The following is a description of a gene set: Male steroid hormones in cardiomyocyte energy metabolism studied in species Homo sapiens Human Gene Set: WP_MALE_STEROID_HORMONES_IN_CARDIOMYOCYTE_ENERGY_METABOLISM, and this is the list of marker genes: HSD17B2, HSD3B2, HSD3B1, HSD17B14, CYP11A1, SRD5A2, HSD17B3, AKR1C3, CYP17A1, UGT1A1, CYP19A1, SULT1A1, SRD5A1